The following is a description of a gene set: Reactome Pathway: FGFR3c ligand binding and activation studied in species Mus musculus part of: FGFR3 ligand binding and activation electronically inferred by orthology from the curated human pathway This event has been computationally inferred from an event that has been demonstrated in another species.<p>The inference is based on the homology mapping from PANTHER. Briefly, reactions for which all involved PhysicalEntities (in input, output and catalyst) have a mapped orthologue/paralogue (for complexes at least 75% of components must have a mapping) are inferred to the other species., and this is the list of marker genes: Fgf20, Fgf17, Fgf23, Fgf5, Fgf4, Fgf1, Fgf8, Fgf2, Fgf16